The following is a description of a gene set: species: Homo sapiens DRG (dorsal root ganglia) genes. Human Gene Set: MODULE_2, and this is the list of marker genes: LAMA4, MAPRE2, S100A8, ID2B, OPTN, BIRC2, GDF15, MBP, PTN, SST, EMP1, S100B, WWTR1, IGFBP4, NTRK2, ALDH1A3, UBE2L6, GNG11, L1CAM, RHOB, MAOB, DDIT4, SLC2A3, AHDC1 (AT-hook DNA binding motif containing 1), RBPMS (NCBI Gene Id 11030), PDGFRB, ABLIM1, CD34, SYNM, LAPTM5, FKBP1B, ENO2, SLC29A1, G0S2, GPC3, MAPK8IP3, CRABP1, MPZ, TSPAN8, DLX4, MARF1, MYL9, FBLN1, AUTS2, ALCAM, ARHGDIG, CADPS, HSPG2, PCDH9, ACTN1, TGFBI, LDLR, NOTCH3, NR4A1, ANGPT1, CD24, DYNLT3, CYB5A, ACTG2, CSPG4, RGL1, ADIRF, GJA1, CRIP1, JUN, PCK1, CALU, DDIT3, CYB5R1, OLFM1, IER3, RABGAP1, MIA, IFI27, COL15A1, ECM2, TFRC, CLDN5, MYLK, CFH, SEC11A, TPM1 (NCBI Gene Id 7168), FGFR1, CFD, CAV1, S100A4, ZIC1, STMN2, CFHR1, AP1S2, INSIG1, PTPRC, TGFBR3, ATP9A, COL6A3, MBNL1, ITGB4, DEPP1, C1S, RARRES2, CXCR4, DTX4, TNFAIP3, ADIPOR2, FADS2, CPE, SYT1, HSPB2, GOT1, GYG1, PLA2G2A, ADH1B (NCBI Gene Id 125, alcohol dehydrogenase 1B (class I), beta polypeptide), FOSL2, FSTL3, ECHS1, SLC25A1, FBN1, TFPI, INA, MAFF, NR4A2, LPIN1, PCOLCE, UGCG, IGF2, NUPR1, STAC, ZEB1, CAP2, LDOC1, ATP6V0A1, EMP3, MMD, SYT11, TGFBR2, KIF5C, SCG2, AKR1C1, MAL, CLIP3, SLC39A6, GPX3, SRPX, FADS1, SPP1, UGDH, PCBP4, RNASE4, COL4A1, TGM2, TNFRSF14 (TNF receptor superfamily member 14), CSRP1, ME1 (malic enzyme 1), AEBP1, DDX3Y, MYH11, HES1, COL6A2, ATF3, TSPAN7, IGHM, TCEAL4, RSRP1, RNF167, CCND2, LMO4, MAOA, RGS5, JCHAIN, ST6GALNAC2, BLVRB, NPY, SLIT2, PER1, ITGA7, APOD, FXYD1, AQP7, CNN1, GBE1, TLE1, MME, ITGB5, TPM2, ITM2A, ANK3, ENPP2, DNAJB2, MX1, LAMB2, H2BC21, SPRY1, CADM3, CYP4B1, PLP1, BCL6, PPP1R12B, TIMP3, CD44, CCND1, CADM1, PLEC, GET1, SCHIP1, CDH5 (cadherin 5), TBC1D2B, GATM, VWF, TNFRSF10B, SMTN, HSPA6, CDKN1C, CRIM1, THY1, USP6, DUSP6, CCL3, SATB1, LTBP2, TNFRSF1B, PTGDS, NGFR, ITPR3, ETS2, PLIN2, CD37, SELENOP, MGLL, PHLDA2, THBS2, TRIM2, DNM1, SOX10, LAMB1, FN1, GAS7, NEFM, RCAN2, DMD, TRIB2 (NCBI Gene Id 28951), GABBR1, SNAP25, SGCE, IGFBP6, CCL2, SCP2, FGF1, NEFL, COX7A1, LUM, SFRP1, DDC, COL6A1, TNXB, VEGFA, ASAH1, MLLT11, FLNA, CD200, JUNB, MFAP4, IGHG3, DDX42, LIPA, GRB10, GOLGA8A, CSF3, RAMP2, SLPI, PDGFRL, IFNGR1, PPP1R15A, PDE8A, GAP43, ABLIM3, CCL15, THRA, TM4SF1, SERPINH1, SERPINA3, ADGRG6, PPT2, SYNGR1, FBLN2, MSMO1, CHL1, CNN3 (NCBI Gene Id 1266), CYP1B1, CCN1, LAMA5, EPB41L2, BMERB1, CDKN1A, EMP2, ERBB3, AHR, ITGA6, LTBP1, HLA-DMA, MTUS1, ADM, CRYAB, STAB1, TMEM47, HLA-DQA1, SRRM2, LRP1, SOD3, APOE, SNAP91, AOC3, TLE2, PTPN13 (NCBI Gene Id 5783), CAV2, PPP1R1A, TNC, CCL21, GNG12, MEGF9, TSPYL2, CLEC3B, ALDH1A1, HLA-DQB1, DST, CXCL12, SEPTIN10P1, GEM, FABP7, ANXA1, ULK1, RGS2, SV2B, FCGRT, EPS8 (NCBI Gene Id 2059), FOS, PDLIM4, PLAAT3, SNCG, RGS1, TSPAN3, RHOBTB3, RBP4, ACKR1, ADH1A, EPB41L3, PECAM1, ARHGEF10, DDX21, IL1R1, FAT1, EEF1A2, ENG (endoglin), VSNL1, NNMT, AQP1, CD151, RTN1, SRGN, DHRS3, RFTN1, MOAP1, LEPR, IGFBP3, NCAM1, CHGB, QDPR, COL3A1, COL1A2, PTP4A3, C7, TBC1D9, SLC6A2, S100A11, DYNC1I1, DPYSL3, BCAS1, AKAP12, NFIL3, LPL, GPNMB, ACSL1, PON2, FABP4, GLS